Given this list of marker genes Cacnb2, Kcne3, Kcne1, Kcnh6, Ace, Ank2, Scn4b, Cacna1d, Bin1, Dsc2, Dsg2, Isl1, Kcnd3 (NCBI Gene Id 99868), Kcnh2, Pkp2, Dsp, Scn2b, Kcne2 (NCBI Gene Id 69143), Kcnj2, Cav1, Kcnq1, Ctnna3, Scn1b, Akap9, Trpm4, Hcn4, Jup, Cacna1c, Scn3b, Cacna2d1, Kcne5, Src, Kcna5, Gja5, Kcne4, Scn5a, Kcnj5, here is a description of the gene set: A cardiac conduction process that modulates the frequency or rate of heart contraction. studied in species Mus musculus Mouse Gene Set: GOBP_REGULATION_OF_HEART_RATE_BY_CARDIAC_CONDUCTION